Given this list of marker genes DNMT3A, CREBBP, TET2, ANKRD13C, FTO, EP300, IRS1 (insulin receptor substrate 1), GGT6, DNMT1, CADM1, HDAC2, YTHDF3, IFITM3, PIP4K2A, NOL9, HDAC1, EZH2, here is a description of the gene set: Human Gene Set: WP_HALLMARK_OF_CANCER_NONMUTATIONAL_EPIGENETIC_REPROGRAMMING Hallmark of cancer: non-mutational epigenetic reprogramming studied in species Homo sapiens